Given this list of marker genes ZDHHC5, DHPS, C1orf174, DIMT1, ZSCAN22, KRT27, RIMKLB, TMEM39A, ECE2, ELAPOR1, SPATS2, PALLD, PLK2, IL18, ZMPSTE24, FCGR2B, SLC39A4, STAU2 (NCBI Gene Id 27067), WBP4, SLC18A1, EMC7, PPIF, GSPT1, GBE1, PTPRE, KTI12, GPN2, CPEB1, HMOX1, MEMO1, SLC31A1, TTC39C, ALDH7A1, GCLM, CLEC4E, PRKCH, LRRC59, CD82, GOLIM4, FRMD6, CGREF1, PPP2R1A, EFHD2, RAB32, FDX1, CPA2, IRX3, MAP3K6, YARS1 (tyrosyl-tRNA synthetase 1), BFSP1, KRTCAP2, ITIH5, ARMC6, BOLL, NHLH1, CPD, BIRC3, HOXC13, GK, SPTB, LSM4, TM4SF20, H2AX, DENR, KIN, ANAPC15, SRSF9, TRMT1L, CSN2, ZNRF1, TMEM119 (transmembrane protein 119), HYAL3, PSMC4, HDGF, BAK1, KRTDAP, FKBP1A, SYT12, MAFG, FBXW11, MAST1, ESD, ACTR1B, PRMT7, COL9A1, PNO1, CD38, ABCF1, MSLN, FSCN1, MYL1, MTFR2, SFRP1, MAP3K8, SRXN1, ELOC, GRK2, GBP2, AGPAT3, USP10, MAP3K5, HOXB9, ZSCAN5B, LEPR, CD200, MBD3, FLNB, P2RX3, TGM2, NAMPT, CCN3, GLRX, HSPBP1, MTMR7, PSMA4, REXO2, ZRANB2, NMUR2, CTTN, SOD2, KLHL25, MTDH, AREG, ZNF354A, ADAM22, USO1, BRD2, CACNA1H (calcium voltage-gated channel subunit alpha1 H), ATF3, KCMF1, NSF, PDE4B, SFXN1, CD14 (NCBI Gene Id 929), PKP4, SMAD9, TSHZ1, C11orf71, FAM98A (NCBI Gene Id 25940), TMEM208, PIK3AP1, GDF9, TNP1, ME1, TBX1, PUS7, SLC6A13, PSMB2, GPN3, PTTG1IP, TCTE1, PUM3, HK2, WNK4, EPHA6 (EPH receptor A6), MT4, PMVK, IGF2BP1, REPS1, RBM7, NECTIN2, PPBP, TDRD7, BBLN, CHIC2, MDFIC (MyoD family inhibitor domain containing), TAGLN2, FAM50B, PACSIN3, MYLIP, CD3E, GJC1, MMP14, GEMIN6, CHMP2A, RAD23A, CCL5, CDH3, OLR1, LMO4, SCRT1, NUBP1, MMP2, BHLHE41, IL1RN, SLC25A13, GKAP1, RRP7A, UFSP2, ZNG1B (Zn regulated GTPase metalloprotein activator 1B), RRP12, NLGN1, UBXN8, PDE6D, ZBP1, FABP3, MOB4, GPAM, TFPI, here is a description of the gene set: from publication Amit I, Garber M, Chevrier N, Leite AP, Donner Y, Eisenhaure T, Guttman M, Grenier JK, Li W, Zuk O, Schubert LA, Birditt B, Shay T, Goren A, Zhang X, Smith Z, Deering R, McDonald RC, Cabili M, Bernstein BE, Rinn JL, Meissner A, Root DE, Hacohen N, Regev A (PMID 19729616) species: Homo sapiens mouse primary BMDCs were stimulated with tlr ligands and gene expression changes were profiled on Affymetrix arrays Human Gene Set: GSE17721_CTRL_VS_PAM3CSK4_12H_BMDC_DN Genes down-regulated in comparison of control dendritic cells (DC) at 12 h versus those stimulated with Pam3Csk4 (TLR1/2 agonist) at 12 h.